Given this list of marker genes HLA-DQB1, SPG11, PIGU, TSFM, AFF3, FREM2, MMP23B, MAF, CD109, ATM, MMP19, MFRP, TUBB3, RGS9BP, RPGRIP1, BBS10, NFIX, ELMO2, OPN1SW, COL18A1, NDUFS1, PRSS56, ARSA, FZD5, PDE4D, NDUFAF2, CLCN7, SELENOI, KIAA1549, CTLA4 (cytotoxic T-lymphocyte associated protein 4), PDZD8, GABRA2, ALPK1, IL12A-AS1 (NCBI Gene Id 101928376), WARS2, ZNF513, RP9, GPR101, IDS, CPSF3, PPT1, CREBBP, ZEB1, AGTPBP1, KLHL7, RGS9 (regulator of G protein signaling 9), FANCB, LONP1, HDAC4, GATA1, HPS4, SLC25A4, TINF2, SEPSECS, IL17RD, BBS12, SYNJ1, RIMS2, TYR (NCBI Gene Id 7299), SNRPN, POU3F4, EXOSC3, H4C3, PRPF6, MERTK, AP4S1, SF3B2, GTF2IRD1, NEUROD2, YAP1, KIF1C (kinesin family member 1C), LAMB2, MT-ATP6, CACNA1I, PORCN, NMNAT1, FLVCR1, ACTB, LRIT3, ELP4, HMBS, ATN1, CA4, AIPL1, ERCC2, LIM2, TUBGCP6, MAPKAPK3, LMNB1, RS1, ARL2, HLA-B, KAT6A, NDUFAF5, PEX3, LRMDA, APC, ERCC6, GNAT1, RFC2, POC1B, HESX1, DISP1, FGFR2, TMEM231, PEX5, AHDC1, MT-CO1, CCDC28B, FILIP1, GLYCTK, AP1G1, COL4A1, CLEC3B, KIF21A, RAD51C, BAP1, BOLA3, AP4M1, TULP1, ARSG, HLA-A, EYS, GRIP1, PRPF8, CEP120, NEK2 (NIMA related kinase 2), NDUFB3, CNGB3, TGFBR3, AGO2, PIGA, OAT, NOTCH3, NAPB, AMACR, CHD3, SLC31A1, YARS1, AFG2A, ELN, GLRX5, PAX6, RPE65, MT-TV, ZNF423, TGFBI (transforming growth factor beta induced), COL11A1, SLC1A3, SMO, MT-ND5, TP53, MT-ND4, OSGEP, PDE6C, BBS5, BAZ1B, GATA2, TRIM44, SH2B3 (SH2B adaptor protein 3), NDNF, WHRN, OVOL2 (NCBI Gene Id 8197), TRPM1, TSEN54, SPRY4, MAK, IL23R, BBS7, IKBKG, EIF2B1, FA2H, AFG3L2, TUBB4A, SPATA7, USP45, COL25A1, NDUFAF4, ENG, JAK2, CSPP1, PDSS2, CFAP410, TWNK, GNB3, TASP1 (NCBI Gene Id 55617), KIF11, AGBL1, CLN6, MTHFS, FXN, PLCB1, MFF, EMC1, CNGB1, TWIST2, LRP5, SLC6A6, RFT1, PPP1R12A, COG3, EARS2, TIMM8A, SALL4, WDR11, RNU12, TRIM32, PAK2, MPL, LZTR1, PUF60, OTX2, PHF6, POLA1 (NCBI Gene Id 5422), RNU4-2, ATPAF2, TSPAN12, NPHP1, CEACAM16 (NCBI Gene Id 388551), TP53RK, CCDC47, TBCK, AARS1, CRYAA, NDE1, RDH5, DUX4, COG5, TAOK1, MTTP, SMG9, FKTN, MARK3, ZFX, IFT88 (intraflagellar transport 88), CD247, KCNV2, SOX11, GMPPB, GRXCR2, PHOX2A, PIK3R2, TFE3, ARL6, B3GALNT2, IDH3B, IFNGR1, SLC52A2, ASNS, XYLT1, CLIP2, DRAM2, CTNNA1, CTC1, CHP1, MT-ND2, TMEM126B, IMPG2, LARGE1, SPTBN4, KCNN2, HARS1, CACNA2D4, IL12B, TERT, PCDH15, CDC42 (cell division cycle 42), SETBP1, NDUFAF1, TTPA, POMT1, EPCAM, MSH6, IDH3A, GDF6, MICOS13, AFG2B, FARS2, DEPDC5, DOHH, PDE6B, PEX11B, CLN5, EIF4H, HEXA, FLRT3, RPGRIP1L, TUBGCP4, PHYH, KCNQ2, TELO2, NEDD4L, RERE, KERA, TPP1, NUBPL, PEX2, TUB (TUB bipartite transcription factor), TOMM7, PEPD, SLC35A2, HKDC1, RBP3 (retinol binding protein 3), CFHR1, EPM2A, NPHP4, NHLRC2 (NCBI Gene Id 54835), PEX26, TBC1D2B, NF2, PPP2CA, ROM1, MT-TF, C1QTNF5, TK2, COQ7, TENM3, PEX13, NUS1, HMX1, PRDM16, CTSD, ASB10, SHANK3, CLCN6, VPS13B, PIK3CA, NODAL, GPR143, NTRK2, MMP1, MT-CO3, TTI1, LETM1, ZNHIT3, RAC1, CACNA1E, CAMK2B, RAX2, SOBP, SDCCAG8, CNTNAP1, RP1L1, ANKRD55, KCNJ13, BRAT1 (BRCA1 associated ATM activator 1), NDUFA6, SRD5A3, SLC25A19, TRAPPC2L, ALG3, USH2A, KIF1A, CCDC141, PXDN, HS6ST1, NDP, TWIST1, SYT1, SDHD, AIP (NCBI Gene Id 9049), SMARCD1, MT-TH, KRT12, NDUFB11, AP4B1, FAS, CNNM4, SDHB, ALMS1, PCDH12, TRRAP, CYP4V2, PITPNM3, SDHAF1, CERT1, CEP290, UCHL1, TNFRSF11A, CEP164, TLCD3B, TUBA3D, TRIO, MBD5, REEP6, HLA-DPB1, DIAPH1, ZMIZ1, GNB1, SUCLA2, LYST, FRMD7, GM2A, RAB18 (NCBI Gene Id 22931), ERF, FH, PRPF4, PEX14, UROD, CLP1, NR2F1, UNC119, DCN, PMS2, GRHL2, ESAM, RDH11, TMEM67, ATP1A2, OGT (NCBI Gene Id 8473), OCRL, DPM1, SCN8A (sodium voltage-gated channel alpha subunit 8), CAPN5, BRIP1, USH1C, UROS, IFT140, LAMC3, CHMP1A (NCBI Gene Id 5642), TRAF3IP1, TUBB2B, NDUFS8, POLR1D, MMACHC, SALL2 (spalt like transcription factor 2), PQBP1, VPS37D, H3-3A, GABRB2, PDXK, UBAC2, NDUFB9, PDE6G, ABCA4, PITX3, KRAS, GRIN1, ABCD1, PRRT2, PALB2, SRY, PDE6A, D2HGDH, HMCN1, RRAS2, VCAN, RAB3GAP1, LRAT, NOD2, ELOVL1, BUD23, SLC38A3, STX1A, DLL1, XYLT2, WDR19, ROBO3, RFWD3, FANCI, GP1BA, BCL10, LAMA1, MTRR (5-methyltetrahydrofolate-homocysteine methyltransferase reductase), OSTM1, AKT3, POLR2A, SMC1A, RAB11B, DHX37, GTF2I, POLR3GL, DTYMK, TSEN2, HCCS, RBMX, WDR45B, FLNA, MFN2, MT-ATP8, NSMCE2, SAR1B, IBA57, P4HA2, FANCM, TCOF1, TDO2, CFHR3, FRG1, OPN1MW, ZNF408 (zinc finger protein 408), PRCD, ATP5F1E, COL2A1, SETD5, CDH23, ALDH3A2, RALGAPA1, DNA2, PIGN, NCF1, MTR, HADHA, NLRP1, CLN8, MT-TW, PEX7, NDUFS7, CAMK2A, CFI, TBC1D24, SMARCE1, FOXH1, BTNL2, BEST1, TCIRG1, CABP4, PIGY, CFAP418, KIF5A, KIF14, MT-TL1, PUS3, ARL3, PROS1, BLOC1S3, CEP19, OFD1, LAMP2, POMT2, DLAT, COQ2, BBIP1, TUBA1A, ATIC, VPS11, REV3L, ARID1A, PARS2, CEP250, ADGRV1, RHOA, MT-TS2 (NCBI Gene Id 8020), H4C9, SNX10, GRIK2, ARID2, SLC4A11, LRP2, TSEN34, PDZD7, SLC25A1, FEZF1 (NCBI Gene Id 392779), GTPBP2, NHS, AP1S2, STIL, PDGFB, NAA10, SIX3, LYRM7, ITM2B, AHR, CHKA, MYO7A, IQSEC1, TMEM216 (NCBI Gene Id 51259), COL9A1, DOCK6, GNA11, TTR, FANCC, TEFM, SLC19A2, MIR204, ITGA2, NLRP3, TRAPPC11, KLRC4, CHRDL1, TANGO2, CLCC1, SLC12A5, SNRNP200, SHH, PROK2, NPHP3, FGF12, GJA1, COQ4, CKAP2L, AIMP1, MLX, PIGP, MALT1, ABCC6, DNMBP, NDUFA1, LIMK1, GTPBP3, SLC4A10, ATP5F1A, ARHGDIA, TACSTD2, BRAF, SOX10, SEMA4A, FCSK, TAT, FOXC1, HK1, ANKH, PEX6, C1QBP, PDPN, DPF2, TUBB4B, PLCH1, IKZF1, TSEN15, WFS1, SETD1A, AIFM1, MT-ND3, SAG, EIF2B3, GABRB1, NDUFV2, SLC4A2, ITPR1, GNAT2, SLC39A4, NDUFAF8, TBL2, HLA-DPA1, LTBP2, DPP6, RMRP, CASK, FRAS1, FIG4, ZFYVE26, PGK1, ADAM9, PMS1, ESPN, PROKR2, RGR, SLC38A8, PRKDC, SLC39A14, ARHGEF2, B4GAT1, IMPDH1, PRNP, ZEB2, CACNA1D, BCOR, PRIMPOL, SREBF1, FGFR1, PRKCZ, RNU4ATAC, CEP85L, MED12, NR2E3, DDX3X, FANCG, THSD1, ANTXR1, POLG2, BTD, COX7B, ADNP, PNPT1, RPGR, FANCL, MECR, ERCC1, RDH12, RAB3GAP2, PEX16, DTNBP1, GJB6, ATP1A3, SOST, KIDINS220, HPS5, TACR3, CHEK2, GIPC3, MCAT, TTLL5, SMARCA4, PLG, METTL27, C19orf12, ABCA1, GNAQ, COPB2, USP48 (ubiquitin specific peptidase 48), VAMP2, KMT2B, SEMA3A, DYRK1A, SLC45A2, COL9A2, FANCD2, RD3, NR3C1, FBN2, FSCN2, IL2RB, SLC24A5, CHD6, MT-ND6, KCTD7, PPP2R1A, GJB2, MIR140, GRN, CCND1, PDE6H, RP1, NCAPG2, CBS, CWC27, CDHR1, RORA, HSPG2, NF1, TGIF1, SH3BP2, AP3B1, SMCHD1, NDUFB10, GUSB, DUX4L1, TET2, CALR, ERCC8, TCF4, EIF4A2, PRORP, DUSP6, RTN4IP1, MEN1, MED25, ARX, RAD51, CTNNB1, PAX2, NRL (NCBI Gene Id 4901), RCBTB1, TUBGCP2, ITGB3, TLR4, FBXW7, SDHA, SFXN4, MC1R, COL3A1, RLBP1, WT1, PI4KA, GALC, LSS (NCBI Gene Id 4047), MT-TC, ELOVL4, GRIN2D, NBAS, NDUFAF3, OPA3, COX6B1, SLC7A14, PCYT1A, NDUFS4, POLE (NCBI Gene Id 80252), CYP1B1, PANK4, PCARE, RIMS1, NAGA, GLI2, SLC25A22, FKRP, IFT172 (NCBI Gene Id 26160), STX3, KIF3B, IMPG1, PEX19, GNAS, SPTBN1, PGAP1, MT-TK, CCR1, TIMP3 (TIMP metallopeptidase inhibitor 3), ADARB1 (adenosine deaminase RNA specific B1), ATF6, BMPR1A, BIRC3, GPR179, DCT, NDUFA11, SCLT1, CDK8, SOX2, ARNT2, PEX10, PYCR2, USH1G, VWA8, SOX3, SSBP1, HPS6, MAD2L2, CHN1, VPS51, FDX2, DNMT3B, MPDZ, MFSD8, AP3D1, FBXL4, PLXND1, PEX12, BBS9, TMEM126A, CLCN2, CLTC, MAG, CNGA3, OPN1LW, COL7A1, IL2RA, ADAMTS10, MICU1, DHDDS, USP8, RNASEH1 (ribonuclease H1), NYX, ATRX, TMEM98, MAFB (NCBI Gene Id 9935), TMEM138, ZIC2, DOCK7, CRYGC, BMP4, PTCH1, POMK, ATOH7, SCO2 (synthesis of cytochrome C oxidase 2), STAT4, ZNF469, PUM1, ATXN7, FDFT1, CRB1, PTPN22, NDUFV1, PMPCB, BLOC1S5 (biogenesis of lysosomal organelles complex 1 subunit 5), RRM2B, CRIPTO, FOXP1, MLXIPL (NCBI Gene Id 51085), PLK4, BRCA1, GTF2IRD2, PRDM5, GPAA1, RNF13, WDPCP, TRAPPC12, FZD4 (NCBI Gene Id 8322), ARPC4, ITGA2B, GUCA1B, MT-TQ, CLRN1, HPS1, TIMMDC1, ARID1B, POLG, MEFV, CYP27A1, UFC1 (ubiquitin-fold modifier conjugating enzyme 1), ERCC4, HGSNAT, ALG2, TBX1 (T-box transcription factor 1), TBC1D20, KCNT1, MTFMT (mitochondrial methionyl-tRNA formyltransferase), PNPLA6, EPRS1, IL12A, NEU1 (NCBI Gene Id 4758), POLR1B, NDUFS3, FTH1, NDUFS2, CTNS, IGBP1, MYOC, WDR26, SV2A (NCBI Gene Id 9900), POLD1, DLD, FKBP6, PSAP, CHD7, FOXE3, DCC (DCC netrin 1 receptor), IL10, WDR45, COL17A1, PIGT, LCA5, FBN1, PRPF3, MUTYH, PIGS, FAM161A, COX11, INVS, B3GAT3, PANK2, MAPK8IP3, AFF4, MSX2, AKT1, PLA2G6, NARS2, OPA1, MSH2, ERCC5, CDC42BPB, COL9A3, CNGA1, EFEMP1, RBP4, BDNF, PRTN3, LCAT, LRPAP1, TFG, IQCB1, HEXB, CRYBB1, NDUFS6, FDXR (ferredoxin reductase), TTC8, TEK, TNFSF11, KCNAB2, VSX1, NADK2, SCYL1, HSD17B4, STAG2, CIB2, C4A, ANOS1, POMGNT1, IFT74, SCAPER, BBS4, GP1BB, AAAS, SMARCC2, POGZ, BBS1, SUOX, UBE2T, SCN1A, SCN3A, CERKL, MT-ND1 (mitochondrially encoded NADH:ubiquinone oxidoreductase core subunit 1), PIGB, SH3TC2 (NCBI Gene Id 79628), PRR12, COL8A2, ASPA, THPO (NCBI Gene Id 84434), PROM1 (prominin 1), AGBL5 (NCBI Gene Id 60509), INPP5E, CAMSAP1, FOXRED1, PLOD1, VRK1, SCN2A, CASZ1, KARS1, PET100, ARL2BP, XRCC2, IFT43, YME1L1, EXOSC9, ARMC9, APOE, MKKS, RAB28, P3H2, BBS2, SARDH, CA2, ERAP1, EXOSC8, MCOLN1, PITX2, HLA-DRB1, SAMD7, CACNA1F, CRLS1, ENPP1 (ectonucleotide pyrophosphatase/phosphodiesterase 1), TMEM270, CLCN4, PIEZO2, CDKL5, PCYT2, TMEM53, AP4E1, FANCF, HPS3, HSD17B10, ATP6V0A1, FN1, XRCC4, MIEF1, MIR184 (microRNA 184), P4HTM (prolyl 4-hydroxylase, transmembrane), AMPD2, CHM, RPS20, HIKESHI, GMPPA, KIAA0586, PDHA1, SKI, GDF3, MAP3K7, YIF1B, ACO2, TRAF7, CSF1R, MTRFR, ADAMTSL4, CLN3, SLX4, CACNA1B, UFM1, LMBRD2, DNM1L, KMT2D, CACNA1A, ST3GAL5, LZTFL1, FGFR3, GRM6 (NCBI Gene Id 2916, glutamate metabotropic receptor 6), PRPH2, TGFBR2, RIC1, DNAJC30, CHST3, LUZP1, CEP78, THOC2, B3GLCT, CARS2, PLEKHM1, PHGDH, FGF8, TOPORS, PRDX1, CEP41, SPEN, GAS1 (NCBI Gene Id 2619), CDH3, SOX4, UBAP2L, CFH, EBP, ACBD6, AHI1, ASPH, NOG, DDR2, MTOR (mechanistic target of rapamycin kinase), DOLK, AIRE, TMEM237, RP2, GUCA1A, GUCY2D, GSN, GABRD, PRPF31, PTPN2, FANCE, SLC25A46, CDON, PRPS1, CRX, MT-ND4L, MT-CO2, GRK1, PRUNE1 (prune exopolyphosphatase 1), TRNT1, WASF1, MKS1, DHX38, ANKRD11, SUFU, MLH1, CHST6, H1-4, CYSLTR2 (NCBI Gene Id 57105), MACF1, VPS4A, CC2D2A, OCA2, FGF17, PLA2G5 (NCBI Gene Id 5322), ISCA2, SMARCB1 (SWI/SNF related, matrix associated, actin dependent regulator of chromatin, subfamily b, member 1), FANCA, GRM7, KANSL1, PIGQ, SLC24A1, HPDL, KIZ, BRCA2, FOXL2, SON, ATP5MK, SUMF1, POLR1C, ADAMTS17, ADA2, PPP3CA, VHL, TREX1, CACNA2D1, HECW2, IFT27, MAB21L1, ATP5F1D, ARHGEF18, GLB1, ANGPTL6, RHO, WAC, CRPPA, GNS, PSMD12, UBE4B, MT-CYB, SF3B1, PEX1, here is a description of the gene set: Visual impairment (or vision impairment) is vision loss (of a person) to such a degree as to qualify as an additional support need through a significant limitation of visual capability resulting from either disease, trauma, or congenital or degenerative conditions that cannot be corrected by conventional means, such as refractive correction, medication, or surgery. Visual impairment Human Gene Set: HP_VISUAL_IMPAIRMENT studied in species Homo sapiens